Given this list of marker genes Kat2a, Msi1, Nes, Psph, Aldh1l1, Prom1, Msi2, Pax6, Fabp7, here is a description of the gene set: Mouse Gene Set: HEVNER_CORTEX_NEURAL_STEM_AND_PROGENITOR_CELLS from publication Bedogni F, Hevner RF (PMID 34321999) Genes selectively expressed by neural stem cells and progenitor cells in embryonic day 14.5 mouse cortex species: Mus musculus